The following is a description of a gene set: from publication Wirth TC, Xue HH, Rai D, Sabel JT, Bair T, Harty JT, Badovinac VP (PMID 20619696) species: Homo sapiens Human Gene Set: GSE21360_PRIMARY_VS_TERTIARY_MEMORY_CD8_TCELL_DN The transcriptome of naive OT-I T cells was compared to memory CD8 T cells after 1, 2, 3, or 4 infection with ovalbumin expressing Listeria monocytogenes (LM-OVA). Genes down-regulated in memory CD8 T cells: 1' versus 3'., and this is the list of marker genes: IL15RA, USP6NL, EDEM1, PMAIP1, CXCL11, TRA2A, IFI35, TCN1, NAPA, CLDN10, CD69, IL1B, CUL1, LITAF, TRIM25, TSC22D3, NUCB1, SSTR2, PSME2, LINC03124, TRAF1, ICAM1, SMPD1, PRPS2, PLEK, PIM1, SCO2, PTAFR, CD83, RALB, PI4KB, NRP2, CERS6, CCRL2, TNFRSF1A, LCP2, CEBPA, LAMP3, ZNF200, P2RX7, TBC1D2B, TNFSF9, IL10RA, AK4, BCL2A1, TNFAIP2, PTPN6, IL6 (interleukin 6), SDC4, TAP2, FYB1, GUCY1A1, S100A3, TRIB1, CDKN1A, MAN1A1, FIG4, XBP1, PTGER4, DYRK4, RRBP1, IL2RA, BLZF1 (basic leucine zipper nuclear factor 1), ZNF410, TRAFD1, RNF19B, PSMB8, ILF2, JAK2, CIITA, CDC42EP2, CMAHP, MTF1, CDKL5, EYA3, BATF, ISG20, SAMD4A, CTSZ, IRF1, B4GALT5, IL15, TAP1, ANKS1A, ACVR1B, CCL8, STAT2, CASP10, CTNS, SASH1, N4BP2L1, FEM1C, KIF2A, APOL1, HIVEP2, IRF7, DNAJA2, LMNB1, IDO1 (indoleamine 2,3-dioxygenase 1), BPGM, ICAM4, LIMK2, RCN1, PDE4DIP, DYNLT1, IL3RA, JMJD6, EPB41L2, UBE2L6, SERPING1, VWA8, DUSP5, ADGRE5, SERTAD2, CXCL9, EIF1, SPTBN1, SOCS1, STAT4, CYP1A1, PLAAT4, MEP1B, OAS2, PDGFB, CXCL10, SERPINB2, SBNO2, VPS9D1, ATXN7, DENND4A, GEM, SECTM1, NPC1, IL1RAP, CCL5, CD38, P2RX4, UBB, CD47, FCGR1A, ARHGEF11, MR1, P2RY14, IRF4, IFITM1, VAMP5, TXN (thioredoxin), ATP1B1, H3C10, PRPF3, JUNB, JUN, GBP2, IRF5, WARS1, GK (NCBI Gene Id 2710), NDUFA9, ARID5A, PTPN2, RBMS1, TYMP, FZD7, GPR107, RRP8, GADD45B, SLC31A2, EZH2, RAB32, RERE, XPNPEP1, ZFP36, MCL1, PIM2, NECTIN2, CSRNP2, IFI27, STAT5A, CCL7, PSMB9, F3, ST3GAL5, CASP4, SEPHS2, GADD45G, TNF, CCL18, IRF8, RHOH, RBCK1, SP110, TRIM26, C1QB, ITGA4, MACF1, HSD11B1, GBP1, SOCS3, PNPLA4, KCNS1, KRT12